The following is a description of a gene set: electronically inferred by orthology from the curated human pathway This event has been computationally inferred from an event that has been demonstrated in another species.<p>The inference is based on the homology mapping from PANTHER. Briefly, reactions for which all involved PhysicalEntities (in input, output and catalyst) have a mapped orthologue/paralogue (for complexes at least 75% of components must have a mapping) are inferred to the other species. part of: MyD88 cascade initiated on plasma membrane; MyD88:MAL(TIRAP) cascade initiated on plasma membrane species: Mus musculus Reactome Pathway: IRAK1 recruits IKK complex, and this is the list of marker genes: Ube2v1, Peli2, Ubb, Ikbkb, Irak1, Ube2n, Rps27a